The following is a description of a gene set: Mouse Gene Set: CUI_T_CELL_CD8_IL15_RESPONSE_UP Genes positively differentially expressed in cell type: CD8+ T cell upon treatment with cytokine: IL-15 in mouse lymph nodes in vivo. Cytokines mediate cell-cell communication in the immune system and represent important therapeutic targets. A myriad of studies have highlighted their central role in immune function, yet we lack a global view of the cellular responses of each immune cell type to each cytokine. To address this gap, the authors created the Immune Dictionary, a compendium of single-cell transcriptomic profiles of more than 17 immune cell types in response to each of 86 cytokines (>1,400 cytokine-cell type combinations) in mouse lymph nodes in vivo. A cytokine-centric view of the dictionary revealed that most cytokines induce highly cell-type-specific responses. For example, the inflammatory cytokine interleukin-1β induces distinct gene programmes in almost every cell type. A cell-type-centric view of the dictionary identified more than 66 cytokine-driven cellular polarization states across immune cell types, including previously uncharacterized states such as an interleukin-18-induced polyfunctional natural killer cell state. from publication Cui A, Huang T, Li S, Ma A, Pérez JL, Sander C, Keskin DB, Wu CJ, Fraenkel E, Hacohen N (PMID 38057668) studied in species Mus musculus, and this is the list of marker genes: Ube2n, Polr3d, Pfn1, Surf2, Ddx39b, Timm10, Swi5, Sf3b3, Atp5mf, Dnttip2, Ndufb4, Lsm12, Dnaja2, Tapbpl, Phf11b, Prelid3b, Gimap4, Eny2, Atf4, Phb2, Nop58, Snrpd2 (small nuclear ribonucleoprotein D2), Hsp90ab1 (NCBI Gene Id 98078), Eif3j1, Ssrp1, Prkar1a, Aatf, Tcof1, Umps, Cycs, Pgam1, Alkbh1, Bzw2, Hsd17b12, Idh3a, Ssr4, Yrdc, Mrpl17, Psmd6, Isg20, Atp5mc1, Nampt, Mak16, Vasp, Cars1, Larp4, Btf3, Llph, Lat, Psmg4, Zfp706, Snrpa1, Hnrnpc, Tmed2, Wars1 (tryptophanyl-tRNA synthetase1), Rcc2, Psmd14, Tmem147, Polr1d, Ptma, Ruvbl2, Serpinb9, Rars1, Gart, Wdr83os, Hopx, Lta, Hspe1, Eif4g1, Ndufaf8, Cct2, Sf3b5, Gnl1, Ddx18, Utp18, Tmem238, Sumo2, Ldha, Hspa5, Pdia3 (protein disulfide isomerase associated 3), Oasl2, Mrps5, Ly6e, Ndufa4, Ly6c2, Rnf126, Emc6, Cfl1, Psma3, Psat1, Tuba1b, Noc2l, Ybx3, Pfdn6, Mrpl52, Lyar, Lars1, Stip1, Rbx1, Nlrc5 (NLR family, CARD domain containing 5), Brix1, Pdcd5, Mrpl12, Lcp1, Ifng, Impdh2, Cops6, Eif1 (eukaryotic translation initiation factor 1), Psmb8, Npm3 (NCBI Gene Id 18150), Ifrd2, Sub1, Calm1, Wdr75, Agpat5, Timm17a, Pebp1, Lsm4, Txnl4a, Psmd7, Dnajb11, Phgdh, Psma6, Ccdc124, Cox6a1, Ruvbl1, Pus7, Larp1, Cdc34, Zfp593, Hnrnpdl (heterogeneous nuclear ribonucleoprotein D-like), Mrpl36, Mrps17, Npm1, Ftsj3, Hspa9, Ssb, Mrpl35, Ddx39a, Psma4, Irf1, Drap1, Polr2h, Ly6a, Nop2, Jund, Fbl, Srsf7, Ppid, Timm8a1, Mrps34, Pabpc4, Hsp90aa1, Hspa8, Hnrnpk, Tkt, Phf5a, Ddx27 (NCBI Gene Id 97020), Psmb9, Psmb5, Pgk1, Flt3l, Hnrnpa0, Irgm1 (immunity-related GTPase family M member 1), Atic, Chchd1, Phb1, Fkbp2 (NCBI Gene Id 14227), Lsm7, Glrx3, Mthfd1l, Mcm5, Yars1, Rbm3, Gzmb, Timm9, Tuba4a, Arhgdia, Ung, Pals2, Aen, Gps1, Ak2, Cdv3, Wdr46, Bcap29, Mrpl19, Hint1, Psma5 (NCBI Gene Id 26442), Ube2s, Nedd8, Timm13, Sp110 (Sp110 nuclear body protein), Ppia, Nucks1, Nip7, Cnbp, Pa2g4, Cct3, Ube2m, Uqcc4, Snrpd1, Eif5a, Farsb, Hspbp1, Mtap, Fkbp4, Cct7, Serbp1, Cox6b1, Higd1a, Znrd2, Mettl1, Naa50, Nol12, Aars1, Snrpa, Mydgf, Ndufa12, Gnl3, Psme2, Rab5c, Daxx, Irf8, Chmp4b, Snrpe, Magoh, Fam162a, Tars1, Shmt1, Trp53, Lman2, Dnajc2, Cct8, Mrto4, Eif4a1, Eif3c, Selenow, Gtpbp4, Mthfd2, Tomm40, Ywhae, Rtp4, Rbbp7, Ppig, Cdk4, Erap1, Pdia6, Igtp, Exosc5, Gapdh, Smchd1, Denr, Atp5pf, Aldoa, Rsl24d1, Chchd4, Xbp1, Cox5b, Eif1a, Ifi27, Ran, Nasp, Tpm3, Mif, Srm (spermidine synthase), Cebpz, Slamf7, Shmt2, Rrp15 (NCBI Gene Id 78140), Esf1, Exosc4, Ipo5, Cyc1, Snrpd3 (small nuclear ribonucleoprotein D3), Psma1 (NCBI Gene Id 26440), Cdca7, Gzma, Slfn5, Iigp1, Nifk, Zbp1, Strap, Prmt1, Ifi206, Mrpl51, Ybx1, Nudc, Mtdh, Ndufaf4, Mcm6, Rbm17, Ppan, Abcf1, Bop1, Dbnl, Pum3, Mrpl23, Polr2f, Tubb4b, Pole4, Rrp1b, Nop56, Mrpl15 (NCBI Gene Id 27395), Tcerg1, Srsf9, Hnrnpab, Psmb2, Srsf6, Bcl3, Lsm2, Eif2s2, Eloc, Mars1, Gars1, Galk1, Set, Mdn1, Sdf2l1, Romo1, Cltb, Hspa4, St13, Trim12c, Tap1, Arpc1b, Eif2s1, Parp14, Slc29a1, Eif3g, Ppp1r11, Txn2, Lap3, Txndc17, Eef1e1, Snrpb, Rbmxl1, Mrps28, Sar1a, Rexo2, Exosc8, Mrps18b, Psmb3, Metap2, Wdr18, Sdhb, Rsl1d1, Utp3, Atp5f1d, Pfdn2, Nap1l1, Wdr12, Aimp2, U2af1, Pkm, Cox5a (NCBI Gene Id 12858), Cox7b, Stat1, Ndufa5, Syncrip, Atp5mk, Srsf3, Eif6, Sem1, Psmb4, Clic4, Pes1, Xaf1 (NCBI Gene Id 327959), Hnrnpa3, Psmb6, Magohb, Wdr77, Slc7a1, Wdr43, Ostc, Ctsz, Acot7, Kmt5a, Snx3, Tmed9, Eif4a3, Psma7, Prpf31, Atp5pb, Fabp5, Prdx1, Gbp4, Dad1, Fubp1, Banf1, Znhit6, Srsf10, Snu13, Ranbp1, Cd8a, Mrpl42, Coro2a, Mbd3, Psmd13, Dctpp1, Krtcap2, Slc3a2 (NCBI Gene Id 17254), Igfbp4, Cndp2, Rpf2, Tapbp, Adh5, Srsf2, Ndufab1, Oas3, Dynll1, Comtd1, Eif3a, Mrpl33, Pim2, Mat2a, Polr1g, Ddx21, Rpn1, Mrpl54, Samhd1, Uchl3, Eif3b, Acsl5, Ufm1, Ncl, Mrpl20, Jaml, Apex1, Ubl4a, Nop16, Hdgf, Bzw1, Fam136a, Irf7, Dtx3l, Slfn1, Cish, Tma16, Gcsh, Pfkp, Ddx24, Txn1, Hnrnpu, Mrpl30, Ndufs6, Nop14, Nop10, Mndal, Ebna1bp2 (EBNA1 binding protein 2), Edf1, Eif2ak2, Etf1, Ddx1, Kcnq1ot1, Elob, Mdh2, Agfg1, Ube2l3, Nmi, Imp4, Lgals3bp, Ssbp4, Tbca, Socs1, Calr, Timm50, Sdad1, Uqcr11, Snrpf, Noc4l, Uqcc2, Actg1, Eef1g, Ifi47 (NCBI Gene Id 15953), Psmd12, Alyref, Bst2, Ifi209, Mrps14, Naa20, Abcf2, Pim1, Aldh18a1, Ltv1 (LTV1 ribosome biogenesis factor), Clns1a, Mrpl21, Mcm2, Ifi208, Eno1, Agpat3, Uqcrq, Manf, Atp5mc3, Rnf213, Uck2, Tomm20 (translocase of outer mitochondrial membrane 20), Casp8, Thumpd1, Dcun1d5, Cdk6, Hprt1, Chchd2, Socs3, Tipin, Iars1, Isg15 (NCBI Gene Id 53606), G3bp1, Hspd1, Parp9, Ndufa11, Fkbp1a, Stat3, Vars1, Grwd1, Grpel1, Abce1, C1qbp, Canx, Psmc4, Eprs1, Pin1, Nudt5, Eif5b, Smc1a, Bax, Cct5, Utp20, Smyd2, Gadd45gip1 (growth arrest and DNA-damage-inducible, gamma interacting protein 1), Anp32e, Trir, Ptges3, Gbp7, Ppat, Gpatch4, Utp14a, Mrpl57, Psme1, Tmed10 (transmembrane p24 trafficking protein 10), Hnrnpf, Ndufb7, Ahsa1, Pusl1, Nhp2, Treml2, Nsun2, Psme3, Caprin1, Aprt, Rrp1, Bysl, Vdac2, Tomm5, Mybbp1a, Rras2, Commd1, Rrp9, Eif4ebp1, Ndufb6, Odc1, Slc25a5, Eif3m, Eif4e, Ywhab, Hsp90b1, Arpp19, Il2rb, Vim, Cox7a2, Gadd45g, Mrps24, Dph3, Nolc1, Rrs1, Rigi, Tcp1, Gspt1, Hnrnpd, Lsm6, Ifit3, Ppp1r14b, Pdcd11, Usp18, Kars1, Gbp2, Ssr2, St6galnac4, Gpr18, Dkc1, Capg, Ddx54, Sars1, Atp5f1b, Hnrnpa2b1, Psmb10, Mthfd1, Ndufb9, Rwdd1, Mphosph10, Tpi1, Pomp, Ccdc86, Cct4, Ifit1, Psmc5, Kpnb1, Nars1, Mrps15, Pno1, Eif3d, Eif1ax, Gbp9, Stoml2, Jpt1, Gar1, Uqcrb, Pcbp1, Taf10, Fasn, Bcl2, Trim30a, Psmb7, Mcm3, Ppa1, Rbm8a, Plac8, Cfdp1, Atad3a, Tmed5, Anp32b, Uqcr10, Cdc37, Cacybp, Nme1, Ccnd2, Calhm6, Ifi35, Tfdp1, Pdap1 (NCBI Gene Id 231887), Psma2, Sfxn1, Ndufc2